The following is a description of a gene set: Human Gene Set: FOXC1_TARGET_GENES species: Homo sapiens from publication Yevshin I, Sharipov R, Kolmykov S, Kondrakhin Y, Kolpakov F (PMID 30445619) Genes containing one or more binding sites for (FOXC1) in their promoter regions (TSS -1000,+100 bp) as identified by GTRD version 20.06 ChIP-seq harmonization., and this is the list of marker genes: TNFSF15, ANKS3, CLDN7, ENSAP1, B4GALT3, SLC17A8, CCRL2 (NCBI Gene Id 9034), ABCA13, LRP1, SNORA16A, GAPDHP62, LINC01132, CENPP, NCOA7, CALN1, UBXN8, ECE2, ENSG00000265069, FNDC3B, RPL6P21, ASH2L (NCBI Gene Id 9070), PNLIPRP1, TTR, EFTUD2 (NCBI Gene Id 9343), TMEM202-AS1, MARCKS, NR2F2-AS1, TMTC2, TRIM52-AS1, FABP5, ATXN2, CRYBG2, CPLANE1, PFN3, FOXP2, RPS18, AOAH, RNU6-1327P, PPP1R3F, IL4R, MIR4277, PCYOX1, AFG2B, BOC, LNMICC, PSMA4, ITGB2, MIR6729, NUP214, SHANK2, LINC00640, RPS25P9, MIIP, XPNPEP1, CHD2, VILL, RHBDF1, VPS52, NOL8, FAF1-AS1, ZYX, MIOS-DT, PTH1R, LINC02666 (NCBI Gene Id 107984280), RN7SL187P, LTBP3, SMG6, PLD2, ABCG1, TUBA1A, SNORA80C, DCP2, HSPG2, OGFOD3, TUBA1C, ZNF638, NTRK2, SCAND2P, RPTOR, NCOR2, KRT27, LINC01671, CSF2RB, SEH1L, IVD, STEAP2, SNHG12